Given this list of marker genes SEC61A1 (NCBI Gene Id 83289), STING1, IFNGR1, NFKBIA, PDCD1, NLRP1, PGM3, PSMB8, NCKAP1L, CD247, FASLG (NCBI Gene Id 356), POMP, IKBKG, IL7R, DOCK8, IPO8, FAS, TPP2, STIM1, IL2RB, IL2RG, CASP10, CCND1, TGFB1, RASGRP1, IFIH1, CARD10, here is a description of the gene set: An abnormally increased level of immunoglobulin G in blood. species: Homo sapiens Human Gene Set: HP_INCREASED_CIRCULATING_IGG_CONCENTRATION Increased circulating IgG concentration